Given this list of marker genes H3c6, H4c9, H4c4, Snord118, Crlf2, Adgra2, H2ac11, Etv4, Slc17a6, H2bc18, H2bc11, Snord13, Saxo1, Tnnt1, Fubp3, Prc1, Esrrb, Tmem191, Prdm14, H1f2, Olfm3, Gm11335, Rbks, Cdk15, H1f4, Gtf3c6, Wrap53, Babam2, Ak1, mt-Rnr2, mt-Tv, Txnip, mt-Nd1, H1f3 (H1.3 linker histone, cluster member), mt-Tl1, Rnf213, Tomm5, Ddx59, H4c12, Mylpf, Ppdpf, H2ac14-ps, Eapp, Cacng2, Wsb2, Dph3 (diphthamine biosynthesis 3), Tti2, H4c8, H4c2 (H4 clustered histone 2), Rnu11, Snord3a, Gm15441, Slc6a16, Oxnad1, Mllt6, Foxp1, Dusp9, Mtf2 (NCBI Gene Id 97205), Phc1, here is a description of the gene set: species: Mus musculus Mouse Gene Set: RXRG_TARGET_GENES Genes containing one or more binding sites for (Rxrg) in their promoter regions (TSS -1000,+100 bp) as identified by GTRD version 20.06 ChIP-seq harmonization. from publication Yevshin I, Sharipov R, Kolmykov S, Kondrakhin Y, Kolpakov F (PMID 30445619)